Given this list of marker genes MORF4L1, MAPK12, PTK2, UPK3BL1, STYXL1, PDE6H, PLA2G2A, KCNA6, SLC12A5, FGF12, BCL2L1, RNASE3, TDRKH (NCBI Gene Id 11022), ENO3, TMEM63C, CAMK1D, HDAC10, WDR35, MPP2, CTTN, TPD52, CRAT, ZNF823, LRP2, APCS, ACSM3, GPR83, F13A1, EXPH5, ARX, GABRB3, CACNG6, CBLC, CCHCR1, AK7, SCRT1, ALDH7A1, PEX13, KLHDC8B, HIF3A, MED22, CPA6, HHAT, FAM131A, CEP78, PIK3R3, JHY, ACOT7, GOT1 (glutamic-oxaloacetic transaminase 1), SLC15A1, EVI5L, PRMT2 (NCBI Gene Id 3275), ARMCX6, MORN4, ZNF821, CPN2, LRFN1, EPHB6, LAPTM4B, POMGNT1, KCNS2, CNN3, CCT3, LAMC3, EPHX4, TNK2, TMOD4, EMX2OS, AQP9, PLXNB1, CMYA5, ZNF330, POMT1, HCN3, SMCO1, NEDD4, AKR1C3, ZNF22, SRD5A1, NALCN, SYTL2, THSD7B, DMWD, MPZL1, ELF3, HLA-DRA (NCBI Gene Id 7930), SLC25A47, ADORA2B, RBP7, AKAP1, HIVEP3, PCSK5, TACC2, FER, TUBA1A, S100A16, ANK2, BLMH, ASPDH, KLF14, SOX12, MMP9, CLCNKA, ILF3, REC8, PKMYT1, TTYH1 (NCBI Gene Id 57348), SLC34A2, ADGRA1, NKX2-4, TMEM237, VILL, CCDC81, CILK1, SARM1 (NCBI Gene Id 23098), MCU, TSC22D1, ZNF608, TMEM132A, PLCH2, C1QTNF12, ATP9A, YPEL1, PTF1A, REG3A, VANGL2, SPTB, MCAM, TUBA4A, OSCAR, PKD1L2, MS4A15, CD6, LZTFL1, GSN, GPR153, ART1, SLCO6A1, YPEL2, TBX5, AMIGO1, USH1C, CCR9, H2BC18, KIF26B, ESRP1, TENM4, SAMD12, LCMT1, CLEC2L, NREP, ASB2, HRCT1, CRISPLD2, SLC27A1, ABHD17C, MCOLN3, RBPMS2, SLC16A10, CARNMT1, ZCCHC12, LRRC42, NEO1, UBE2E3, VANGL1, ZNF286A, TONSL, WHRN, KIFC3, PRAMEF25, ITM2A, DLC1, STK39, DUSP26, UBTD1, SPTBN2, PTDSS2, GAS2L1, BBS1, AIFM1, ZNF467, CRY1, CRELD1, DLG4, VNN2, RPL7L1, SCN1B, TNFRSF9, LHFPL6, MEX3A, KCNN4, HSD17B14, FEN1, VWA3B, PRLR, ARR3, CNOT11, ELN, BOC, ARHGAP20, here is a description of the gene set: species: Homo sapiens After positive selection in the thymus, the newly generated single positive (SP) thymocytes are phenotypically and functionally immature and undergo apoptosis upon antigen stimulation. In the thymic medullary microenvironment, SP cells progressively acquire immunocompetence. Negative selection to remove autoreactive T cells also occur at this stage. We have defined four subsets of CD4 SP, namely, SP1, SP2, SP3, and SP4 that follow a functional maturation program and a sequential emergence during mouse ontogeny.We used microarray to detail the global programm of gene expression during the maturation of murine CD4 single positive thymocytes from publication Teng F, Zhou Y, Jin R, Chen Y, Pei X, Liu Y, Dong J, Wang W, Pang X, Qian X, Chen WF, Zhang Y, Ge Q (PMID 22022412) Genes up-regulated in comparison of SP2 thymocytes versus SP4 thymocytes. Human Gene Set: GSE30083_SP2_VS_SP4_THYMOCYTE_UP